The following is a description of a gene set: studied in species Mus musculus Mouse Gene Set: GOCC_SPINDLE_MICROTUBULE Any microtubule that is part of a mitotic or meiotic spindle; anchored at one spindle pole., and this is the list of marker genes: Eml3, Capn6, Chmp2a, Chmp1b2 (NCBI Gene Id 74520), Misp, Ttl, Chmp7, Haus7, Cenpe, Haus5, Kifap3, Chmp3, Ccdc57, Chmp2b, Dynlt3, Csnk1d, Arl3 (NCBI Gene Id 56350), Zw10, Cdk1, Aurkc, Cul3 (cullin 3), Bod1 (biorientation of chromosomes in cell division 1), Rmdn2, Clasp2, Aurkb, Cltc, Kif18a, Haus6, Ska3, Parp4, Calm3, Calm2, Map9, Kif11, Haus1, Chmp1b, Haus8, Hnrnpu, Map1s, Haus4, Mtcl1, Tubgcp3, Calm1, Rmdn1, Kntc1, Haus3, Haus2, Polb, Kif3a, Tubg1, Rab11a, Plk1, Aurka, Kif2a, Cep295, Ccsap, Mapre1, Mapre3, Bbln, Chmp4c, Numa1, Birc5, Ska1, Septin2, Chmp5, Pafah1b1, Clasp1, Ska2, Klhl22, Psrc1, Fam161a, Chmp6, Fam110a, Tubg2, Klhl21, Chmp4b, Chmp1a, Rmdn3, Kif18b